Given this list of marker genes MTOR, PIK3CD, EGFR, RPS6KB2, ERBB2, EGF, AKT1, RPS6KB1, PIK3CA, AKT3, PIK3CB, AKT2, here is a description of the gene set: species: Homo sapiens Pathway Definition from KEGG: EGF -> (ERBB2*+EGFR) -> PI3K -> PIP3 -> AKT -> MTOR -> S6K Human Gene Set: KEGG_MEDICUS_VARIANT_ERBB2_OVEREXPRESSION_TO_PI3K_SIGNALING_PATHWAY ERBB2-overexpression to PI3K signaling pathway. Pathway ID: N00034. Pathway type: Variant. Pathway class: nt06262 Pancreatic cancer.